Given this list of marker genes IFNA5 (interferon alpha 5), IFNB1, IFNA21, TNF, IFNA14, IFNA16, IFNA6, IFNA17, IFNA1, NFKB1, IFNA7, IFNA8, IFNA4, IFNA13, RELA, IFNA10, IFNA2, here is a description of the gene set: studied in species Homo sapiens Pathway Definition from KEGG: Tat -> NFKB => (TNF,IFNA,IFNB1) HIV Tat to TLR2/4-NFKB signaling pathway. Pathway ID: N00436. Pathway type: Pathogen. Pathway class: nt06517 TLR signaling. Human Gene Set: KEGG_MEDICUS_PATHOGEN_HIV_TAT_TO_TLR2_4_NFKB_SIGNALING_PATHWAY